Given this list of marker genes FGF17, FGF20 (fibroblast growth factor 20), GALNT3, FGF23, FGF16, FGF5, FGF1, FGF8, FGF4, FGF18, FGF9, FGFR3, FGF2, here is a description of the gene set: Reactome Pathway: FGFR3 ligand binding and activation part of: Signaling by FGFR3 studied in species Homo sapiens FGFR3 is a receptor tyrosine kinase of the FGF receptor family, known to have a negative regulatory effect on long bone growth. Somatically, some of the same activating mutations are associated with hypochondroplasia, multiple myeloma, and cervical and vesical carcinoma.